The following is a description of a gene set: part of: Innate Immune System Immune recognition of pathogen-associated molecular patterns (PAMPs) by pattern recognition receptors (PRR) often activates proinflammatory nuclear factor kappa B (NF-κB) signalling. Lipopolysaccharide (LPS) is a well-known PAMP produced by gram-negative bacteria. LPS is recognized by toll like receptor 4 (TLR4) and is a strong activator of NF-κB inflammatory responses (Akashi S et al. 2003). LPS is also recognized in the cytosol by mouse caspase-11 and related human caspase-4 and caspase-5, which stimulate pyroptosis, a proinflammatory form of cell death (Kayagaki N et al. 2011; Shi J et al. 2015). Key metabolic intermediates in LPS biosynthesis, d-glycero-β-d-manno-heptose 1,7-bisphosphate (HBP) and ADP L-glycero-β-d-manno-heptose (ADP-heptose) were reported to activate the NF-κB pathway and trigger the innate immune responses (Milivojevic M et al. 2017; Zimmermann S et al. 2017; Zhou P et al. 2018; García-Weber D; 2018). ADP-heptose but not HBP can enter host cells autonomously (Zhou P et al. 2018). During infection, ADP-heptose or HBP translocate into the host cytosol where their presence is sensed by alpha-protein kinase 1 (ALPK1) (Zimmermann S et al. 2017; Zhou P et al. 2018). ADP-heptose directly binds and activates ALPK1 (Garcia-Weber D et al. 2018; Zhou P et al. 2018); instead, HBP is converted by host-derived adenylyltransferases, such as nicotinamide nucleotide adenylyltransferases, to ADP-heptose 7-P, a substrate which can then activate ALPK1 (Zhou P et al. 2018). The ADP-heptose binding to ALPK1 is thought to trigger conformational changes and stimulate the kinase domain of ALPK1 (Zhou P et al. 2018). ALPK1 kinase activity in turn leads to the phosphorylation-dependent oligomerization of the tumor necrosis factor (TNF-α) receptor–associated factor (TRAF)–interacting protein with the forkhead-associated domain (TIFA) (Zimmermann S et al. 2017; Zhou P et al. 2018). This process activates TRAF6 oligomerization and ubiquitination, and the recruitment of transforming growth factor β-activated kinase 1 (TAK1)-binding protein 2 (TAB2), a component of the TAK1 (MAP3K7) complex (Ea CK et al. 2004; Gaudet RG et al. 2017). This TIFA oligomer signaling platform was given the term: TIFAsome. TIFAsome-activated TAK1 induces NF-κB nuclear translocation and proinflammatory gene expression. The ALPK1-TIFA signaling pathway has been identified in human embryonic kidney cells, intestinal epithelial cells, gastric cells and cervical cancer cells (Gaudet RG et al. 2015, 2017; Stein SC et al. 2017; Gall A et al. 2017; Zimmermann S et al. 2017; Milivojevic M et al. 2017; Zhou P et al. 2018). In vivo studies demonstrate that ADP-heptose and Burkholderia cenocepacia trigger massive inflammatory responses with increased production of several NF-κB-dependent cytokines and chemokines in wild type (WT), but not in Alpk1-/- mice (Zhou P et al. species: Homo sapiens Reactome Pathway: Alpha-protein kinase 1 signaling pathway, and this is the list of marker genes: TRAF6, RPS27A, TAB2 (TGF-beta activated kinase 1 (MAP3K7) binding protein 2), TAB1, TIFA, ALPK1 (NCBI Gene Id 80216), MAP3K7, UBA52, UBC, UBB, TAB3